Given this list of marker genes DLL4, DLL1, NOTCH1, ADAM10, JAG2, JAG1, ADAM17, here is a description of the gene set: Signaling by NOTCH1 t(7;9)(NOTCH1:M1580_K2555) Translocation Mutant species: Homo sapiens Human Gene Set: REACTOME_SIGNALING_BY_NOTCH1_T_7_9_NOTCH1_M1580_K2555_TRANSLOCATION_MUTANT